The following is a description of a gene set: Hemeralopia A visual defect characterized by the inability to see as clearly in bright light as in dim light. The word hemeralopia literally means day blindness. Human Gene Set: HP_HEMERALOPIA studied in species Homo sapiens, and this is the list of marker genes: NYX, CNGA3, NR2E3, CEP78, GRM6, GUCY2D, ATXN7, SCO2, IFT172, TULP1